The following is a description of a gene set: Binding to a dynactin complex; a large protein complex that activates dynein-based motor activity. studied in species Homo sapiens Human Gene Set: GOMF_DYNACTIN_BINDING, and this is the list of marker genes: BICD2, SNX6, BICD1, GSK3B, SPTBN5, RUFY3, SNX5, BICDL1, BBS4, HOOK3, PAFAH1B1, HTT, RUFY4, MAPT (NCBI Gene Id 8152)